The following is a description of a gene set: Mouse Gene Set: GOBP_CELLULAR_RESPONSE_TO_HYPEROXIA Any process that results in a change in state or activity of a cell (in terms of movement, secretion, enzyme production, gene expression, etc.) as a result of a stimulus indicating increased oxygen tension. studied in species Mus musculus, and this is the list of marker genes: Fas, Foxo1, Cav1, Nox1, Atg7